The following is a description of a gene set: studied in species Homo sapiens The developmental process pertaining to the initial formation of an anatomical structure from unspecified parts. This process begins with the specific processes that contribute to the appearance of the discrete structure and ends when the structural rudiment is recognizable. An anatomical structure is any biological entity that occupies space and is distinguished from its surroundings. Anatomical structures can be macroscopic such as a carpel, or microscopic such as an acrosome. Human Gene Set: GOBP_ANATOMICAL_STRUCTURE_FORMATION_INVOLVED_IN_MORPHOGENESIS, and this is the list of marker genes: NINJ1, NTF4, KLHL12, ALOX5 (NCBI Gene Id 240), UNC5B, WASF2, EGR3, TP53, NAXE, AHDC1, PKM (pyruvate kinase M1/2), CDK5, DAG1, TNFRSF12A, HDAC2, NRXN3, FGFR2, ARHGAP35, FMNL3, WNT6, PKN1, HOXC11, GARIN1B, MYBPC3, JUNB, CFTR, MIR196A1, MIR885, RAMP1, TP63, NFATC4 (NCBI Gene Id 4776), NKX3-1, AGFG1, JAG1 (jagged canonical Notch ligand 1), MIR2355, APLNR, EDNRA, HRG, ATM, CDON, SMAD4, TUBB1, TWIST1, KRT19, NCL (nucleolin), AGTR1, POU5F1, COL15A1, DKK4, AGFG2, GDF15, MESP2, CACNA1S, CDK5R2, MIR329-1, CCBE1, HMOX1, PRKX, TBX5, TGFB3, SPEM3 (SPEM family member 3), TBXA2R, CLDN5, EXT2, ACRBP, PCDH8, SUPT6H, CARD10, ADAMTS15, PLXND1, POGLUT1, RDH10, ANXA2, GDF7, RELA, ADGRG1, LEO1, AKT3, PNLDC1, TXNRD1, MAPK1, LHX5, PTGS2, HMGA2, SHB, AMTN, TBX19, ITGA2B, MIR17, MIR149, ITGA4, HIPK2, OLFM1, KNDC1, CD93, SIX4, MIR1908, FLOT1, OVOL2, ARHGAP22, CASP9, GATA6, EPN2, COL5A2, TGFB1, SLC34A1, AMELX, ANXA3, SCGB3A1, SOX2, NUS1, ATP5F1B (ATP synthase F1 subunit beta), OBSL1, COL2A1, GATA3, IL17F, IRX2, HOXB3, BMP10, EREG, ACKR3, MINAR1, PLXNB2, RDH13, MMP19 (NCBI Gene Id 4327), WNT2B, STRA6, HESX1, BCL2L11, SCRIB, CCDC42, TGFBR1, TCF15, NECTIN2, MTHFD1, PTK2, SERPINF1, CCN1, NKX2-5, POLR1B, NPR3, PGM5, VEGFA, CD34, PGF, CDH13, FGFR1, NF1, MIR19A, NR5A2, HSPB1, LHX1, OBSCN, HS6ST1, RRAS, PRKACA, CX3CL1, NRCAM (NCBI Gene Id 4897), ALX1, POFUT2 (NCBI Gene Id 23275), LMOD1, SDCCAG8 (NCBI Gene Id 10806), YWHAZ, SOX30, GARIN3, NCKAP1, SOX9, EGLN1, NKX2-1, MDK, MIR377, TMOD4, THY1, RIPPLY1, CTNND1, ATP2B4, SPEM1, CCN6, PRCP, CUL3, NPPB, BCL3, IFT57, SIRT6 (sirtuin 6), WNK1, FLT1 (NCBI Gene Id 2321), PFN1, GARIN1A, MICALL1, NFATC2, SPECC1L, TMEM182, WNT3A, TGFBR3, TMIGD2, MAG, CFL1, HDAC7, NOX5, MAPK3, FURIN, TPM4, TMED2, PROX1, AMOTL2, TEK, APOD, MFAP2, CEND1, TWSG1, ITGA8, HDAC9, AGTPBP1, MIR34A, EYA2, CCN3, HDAC1, PLXNA2, ATP5IF1, AIMP1, PLEC, CDX2, ITGB5, MECP2 (NCBI Gene Id 8274), MIR24-1, MIR30B, VAV3, COL6A1, HES1, VANGL2, CASP8, ECSCR, SKOR2, HTN1, SCX, AGO2, COL1A1, WNT10B, CCDC136, ACVR2B, HES7, NLE1, LMOD3, ABCC8 (ATP binding cassette subfamily C member 8), FASLG, TBX3, LIAS, MIR296, ABI1, BMP4, IFT172, RTF1, TMPRSS12, COL5A1, PERP, CBLN1, NPPC, MMRN1, MIR214, ENSG00000285205, DSG2, FGF2, ELK3, SCG2, FOXF1, ANKRD23, B4GALT1, MIR185, RPL7L1 (NCBI Gene Id 285855, ribosomal protein L7 like 1), HSPG2, SKIL, PPARA, CD109, ADPRHL1, PKNOX1, BCAM, FZD4, MAPK7, RHOJ, CTR9, VTN, IL4R, GNA13, MIR10A, KBTBD8, SH3PXD2A, SPPL2C, ENPEP, SEMA5A, DLL1, MPL, CAPN2, WNT16, KLK4, FLNC, TCIRG1, EDA, HIF1A, MIR492, ITGAX, MYH11, TRAF6, TGFBR2, ADAM17, NCMAP, LOXL2, BMPER, CD36, MIR939, FGF9, COL8A2, NFE2L2, GATA5, MMP8, COL8A1, NBEAL2, ANXA1, ROBO1, MKS1, CEACAM1, CAMP, GDF3, MIR487B, NECTIN1, TMEM201, MIR375, RASIP1, PRKCA, PDCD6, DOCK1, CRB1, GPX1, MIRLET7F1, MEOX1, MIR378A, FBN2, HEY1, TSC1, ANGPT2, DUSP1, HHEX, PRKD2, ACTL9, SPRY1, COL18A1, LRP2, CITED2, SPINK2, FAM20C (FAM20C golgi associated secretory pathway kinase), NR4A1, SLC24A4, DLL3, TGFB2, FAM20A, GRHL2, NDP, EPAS1, MEOX2, PPARG, MIR126, OPTC, TGM2, LEP, RGMA, BCL6, CRB2, ESM1, PAFAH1B1, CDX1, WARS2, CNOT1, GBA1, DUSP4, PXDN, ITGB1, MEIS3P1, EPGN, ATP7A, AAMP, APOH, BMP7, MIR10B, ITGB4, CCL24, LATS2, CASP3, ZNF385A, RRP7A, PHOX2A, NKD1, MYH3, PTCH1, PAF1, COL11A1, ECM1, DSCAM, CCL11, PROK2, BMP2, BTG1, FKBP1A, PDGFRB, BBS4, IHH, DYRK1B (dual specificity tyrosine phosphorylation regulated kinase 1B), FHOD3, SLC12A6, CECR2, TERT, EHD2, TEAD2, CXCL8, SPINK5, PIK3R3, IL18, TJP1, FLT4, MIR29A, MSX1, ACTL7A, NOX1, WNT9B, HTATIP2, TREM2, CLUAP1, EGF, TNNT1, ACTL6A, MYL2, VEGFB, S100A1, ERCC2, ADAMTS9, MIR495, GLI3, NRAP (nebulin related anchoring protein), CYP19A1, SDK2, TNNT3, MIR31, GPC1, EGR2, ENG, ODAPH, F3, PTGFRN, PTPN11, GNPAT, ROCK1, PPP1R16B, SHC1, EIF2AK3, FGF8, SPINT2, SPINT1, TGFA, CALCRL, TIFAB (NCBI Gene Id 497189), LAMA3, HEYL, MIR146A, FGF18, SPHK1, MIR125B1 (NCBI Gene Id 406911), CSPG4, TCTN1, ENSG00000233887, STIM1, CRIPTO, TNN, PDGFB, MIR27B, ACTA1, MYF5, ACTG1, MIOS, ERAP1, SHH, ADM, CACNA1H, VEGFD, JMJD8, TBX18, SAT1, COL3A1, ETS2, KAT2A, MAP2K5, SLC39A12, SLC9A8, EPHA1, NGFR, APOLD1, PRKACB, RARG, TBR1, FZD7, GNAS, RARA, COL4A3, NEO1, HIPK1, EPHB3, MBOAT7, CCL8, CNTNAP1 (NCBI Gene Id 8506), APLN, CEP290, NOLC1, EXT1, PLXDC1, MIR320A, GLI2, PTPN20, CYBB, MYOZ2, FUT1, HSPB6, MED12, DOCK5, ZNF219, MIR101-1, ITGB8, MIR30A, SYNPO2L, C5AR1, TENM4, PEF1, FGF1, PDGFA, C1GALT1, DVL2, TNF, HIF3A, RAPGEF3, COL7A1, MIR34C, ANK2, ANPEP, CXCL10, SYNJ2BP, C3AR1, PIK3CG, SPTBN1, JUP, AMOT, KLHL41, IFT52, JAM3, VASH2, STAB1 (NCBI Gene Id 23166), RAMP2, NODAL, FLII, TMEM100, VASH1, WNT1, TCTA, POFUT1, TCAP, PDCD10, CCL2, TMEM215, NEUROG1, MIR30E, SEMA3C, EPHB1, PTPN6, ROBO4, FOXC1, ZNF354C, KDM6B, SDC4, CDC73, SEMA6A, LEPR (leptin receptor, NCBI Gene Id 3953), MIR20A, TAL1, MIR212, CCM2, MIR222, PMP22, GRN, FOXH1, HEY2, TCOF1, SULF1, ARHGAP24, ATOH8, CDH11, MIR26A1, TFAP2A, PLXNA3, OPHN1, EDN2, STAT3, HYAL1, LUZP1, TNMD, MTDH, MYBPC2, CC2D2A, ITGAV, EDAR, MED1, PIK3CD, DCN, RIPPLY2, SPRED1, NOTCH3, PRKDC, TBX6, SYK, VPS33A, KIF16B, WLS, NOTCH2, FOXJ1 (NCBI Gene Id 2302), MIR221, ANKRD1, MIR138-1 (NCBI Gene Id 406929), ZP3, RHOB, CASQ1, ADGRB3, GJA5, ITGB3, FAIM2, EFNA1, DEAF1, MIR515-1 (microRNA 515-1), CNMD, SETD2, MIRLET7B, MYOM2, EFNA3, ITGA5, MIR640, NKX3-2, OSR1, SFRP2, MIR1-1, MYOM1, MAPK14, WNT2, TBX20, TNFSF14, KIF20B, DUSP5, CELSR1, MATR3, MIR410, SLC25A46, CD47, GPNMB, SLC1A1, ST14, PTF1A (NCBI Gene Id 256297), CFLAR, PROK1, ROBO2, TBPL1, TGFBI, MCAM, ARL6, HSPA12B, EDN1, TPPP, E2F8 (E2F transcription factor 8), TULP3, RECK, MIR181B1, PANK2, EFNB2, VPS4B, SPARC, TSPAN12, THBS1, SPACA1, FAT3, BCAS3, EMILIN1, CXCL17 (NCBI Gene Id 284340), MIR200C, SEMA3E, TSPAN18, SUFU, RTN4, XRCC2, PIK3CA, MSX2, NFIB, THBS3, SOX11, ADAMTS1, CHI3L1, CCR2, ADAM12, SP1, NOTCH4, NDNF, CELA1, SOX18, TRIM15, NRP1, JMJD6, FRS2, AXIN2, NAA15, SERPINE1, HES5, TFAP2C, ISM1, SNAI1, ATF2, RBP4, PLA2G3, E2F7 (E2F transcription factor 7), NOS3, SSBP3, MIR18A, HGS (hepatocyte growth factor-regulated tyrosine kinase substrate), LRG1 (leucine rich alpha-2-glycoprotein 1), EXOC4, GHSR, SDK1, IL10, MIR503, RNF213, TEAD4, KLF5, WT1, SASH1, PODXL, NFKB2, VPS13B, PDPK1, VEGFC, ACTN2, MYMX, GDF2, DLX5, THBS4, MYMK, FGF16, DOCK2, TBX1, MIR16-1, RC3H1, ERVW-1, ITGA3, BMPR1A (bone morphogenetic protein receptor type 1A), XBP1, MIR483, PLK2, FBLN5 (NCBI Gene Id 11268), AMOTL1, APAF1, PTPN18, MIR21, SLC31A1, ACVR1, EPHB2, SFRP1, KLK5, ERVFRD-1, PPP2R3A, RS1, CCN2, CYP1B1, SALL4, TYROBP, STARD13, BMP5, MPIG6B, PRKCB, SIX2, MIR494, MYPN, AGGF1, GSC, LARGE1, RNH1, ZNF304, ANGPTL4, RORA, PLCD3, DAB2IP, CTNNB1, ID1, SALL1, AQP1, EMILIN2, EPB41L3, STIL, ACTC1 (actin alpha cardiac muscle 1), MMP20, FOXA1, HNF1B, SKI, SEC24B, FZD6, MIR92A1, ANGPTL6, TFAP2B, CXCR3, ABL1, PLEKHO1, ELF5, DCSTAMP, MFNG, PRKD1, RELN, GPR15, MIR193A (NCBI Gene Id 406968), MIRLET7A1, GCM1, BYSL, TTLL1, KLF2, FOXC2, IL12A, PPP3R1, CD40, MYBPC1, CHAD, FZD3, MIR19B1, ALDH1A3, TTN, FOXP2, FOXB1, QKI, TANC1, SIRT1, CD81, CCDC38, CD160, MESP1, MEF2C, KNL1, IRX3, PTPRB, WHRN, ETS1, RLN2, IL12B, MIR99B, ADGRA2, SRPX2, FOXN4, THBS2, MTHFR, PIK3R6, MFSD14A, PDCL3, SPRY2, GABPA, PRL, EOMES, FGF10, SF3B6, FKBPL, JCAD, TLR3, HOXA11, MSGN1, WNT7A, FHL2, LHX2, MMRN2, CTHRC1, LAMB1, DMP1, ROGDI, DCAF17, LRP8, OTX2, ANGPTL3, GHRL, HOXA7, KRT1, EMC10, MAP2K1, HAND2, PIK3CB, FOXO4, NRXN1, BRCA1, CD53, PFN4, MIR1224 (NCBI Gene Id 100187716), RBM15, ERVH48-1, UBP1, FYN, HS2ST1, MIR143, DAB1, MIR205, RSPO3, SMARCD3, E2F2, MEF2A (myocyte enhancer factor 2A), TNFAIP3, THSD7A (thrombospondin type 1 domain containing 7A), RALA, SIX1 (SIX homeobox 1), PLN, BMERB1, TLX2, PPP3CB, HAND1, MIR137 (NCBI Gene Id 406928), HOPX, PIK3C2A, MIR424, UNC13D, MIR150, SMAD2, MYF6, LFNG, MIR29C, ITGB6 (NCBI Gene Id 3694), TNNT2, CAPN3, LEF1, TET1, PRKAR1A, PALS1, DCANP1, GTF2I, MIR20B, SRF, GJA1, COL4A2, FOXJ2, SEMA4C, PRDM14, C3 (NCBI Gene Id 12266), ADGRB2, CSRP2, STK3, RPS7, MAP2K2, ADGRB1, ADAM9, PECAM1, MIRLET7G, YAP1, MIR1298, PAK4 (p21 (RAC1) activated kinase 4), IFT122, PIM1, VAV2, ADAM15 (NCBI Gene Id 8751), FOXA2, HSBP1, IZUMO1, CAMK1, NPR2 (NCBI Gene Id 4882), SOCS7, HERC1 (NCBI Gene Id 8925), SOX17, CYLC1, POC1B, FZD8, CSRP3 (NCBI Gene Id 8048), NR0B1, MIXL1, ISL1, CEMIP2 (cell migration inducing hyaluronidase 2), PARVA, CAV1, GLMN, TTC21B (NCBI Gene Id 79809), CDK5R1, MIR505, GRID2, NRARP, TBX2, CREB3L1, COBL, DUSP2, ADAMTS5, AMELY, ADM2, CNTN1, ACVRL1, MIR130A, KLHL6, MIR200B, KLF4, CFL2, MIR106B, MIB1, SLC12A2, MYOD1, OTULIN, SLIT2, RBPJ, CAV3, PML, UGT8, TNFAIP2, SMO, HOXA1, RELT, ATP8B1, PAX6, PACSIN2, HLA-G, VASP, IL1B, KCNH1, PROM1, SMAD3, COL12A1, MFGE8, SRPK2, ROCK2, NR4A3, MIR342, PTK7, FJX1, PF4, MIR34B, NEBL, CCDC134, NUP50, SMOC2 (SPARC related modular calcium binding 2), KDM2B, AKT1, AGO1, CDH5, BSG, SBNO2, EPB41L5, MIR132, MIR22, S100A7, MIR217, BMPR2 (NCBI Gene Id 659), MMP2, MYOG, MYH9, CXCL9, JAK1, DLC1, WDR74, RBM46, DLX6, CSF3R, WARS1, INHBA, MAFB, MFN2, MXI1, AR, RGCC, CLEC14A, MIR145, TBX4, GADD45A, TNFSF13B, CLEC1B, IGFBP7, GATA1, TIE1, PTPRJ, VEZF1 (NCBI Gene Id 7716), FZD5, TBC1D20, EMP2, IZUMO3, WDR83, TGIF1, ANGPT4, TM4SF1, PLXNA1, PDGFRA, HMGB1, GPR4, GPI, TCF21, MIA3, LATS1, MEGF11 (NCBI Gene Id 84465), TSC2, MYL9, TMF1, CNOT2, FGFBP1, IL1A, MMP15, ZC3H12A, SP3, MIR30C1, MIR361, SLC40A1, ZPBP2, WNT5A, GPLD1, ESRRB, ACTN1, MTHFD1L, ITGB1BP1, PTPN14, ZFPM1, ANG, TMOD1, MYOM3 (myomesin 3), KDM4C, HOXB13, MYH10, MACROH2A1, WNT4, ABCA2, SMPD3, TNFSF12, SLC4A2, IL6, NOS1, MEIS3, FAP, LEMD2, NOG, DSPP, CX3CR1, IRX1, HPSE, PLCG1, JUN, MYOZ1, APELA, GREM1, GBX2, ENAM, EHD1, OPA1, TAFA5, MYLK3, KRIT1, CNOT3, DMRT2, CDK20, STAB2, MIR23A, MIR199A1, KIF26B, EPHA2, MTMR2, EPHB4 (EPH receptor B4), TPM1, RET (NCBI Gene Id 5979), MYH6, DCHS1, ADTRP, YJEFN3, PAX8, CHRNA7, PTK2B, MIR199B, MIR451A, GDNF, RHOA, PDCL2, ZEB2, RBM20, FIG4 (NCBI Gene Id 9896), GATA4, FOLR1, NRP2, NR2E1, CNNM4, ITGA7, GLUL, WDR1, CLIC4, TYMP, WNT8A, KLK3, STAT1, PTGIS, GRHL3, PDE3B, GAB1, MIR27A, MYBPH, PRICKLE1, PSEN1, EPN1, SLC44A4, NPR1, ADGRG6, GATA2, TRIM71, BRD2, MMP14, MIR210, HOXB1, SOX8, MIR9-1, ETV2, SNAI2, ADAM8, AHI1, CXCL13, TAF10, ITGA2, SMAD1, MYDGF, SEMA4A, FOXD1, CIB1, MIR125A, AXIN1, ERBB2, CCNB1IP1, NPHS1, OCSTAMP, TBXT, FN1, KIAA0319L, NRG3, ARMC5, OR10J5, CALB1, S1PR1, EGFL7, PGK1, WNT3, ZIC3, COL4A1, ATP8A2, NANOG, HOXA5, LRP6, MIR15B, ANGPT1, SH2D2A, SARS1, C12orf43, RFX2, NF2, ADA, TMOD3, LDB1, CLIC3, RIPOR2, MIR206, TMOD2, HOXA3, GRB2, PITX2, NEB, PLLP, HK2, DICER1, NTRK1, ITGB2, ZPBP, BRD3, EHD4, ERCC1, STK4, PAX2, LMOD2, AKAP13, LMO4 (NCBI Gene Id 8543), SOX7, FGF6, BCL10, PDPN, LDB3, ADIPOR2 (adiponectin receptor 2), NOTCH1, DKK1, EYA1, PHACTR4, CCR3 (NCBI Gene Id 1232), SP100, MINAR2, FUZ, MIR15A, CMA1, MMP9, LAMB3, CHN2, PTPRM, DLL4, CD9, RUNX1, VSTM4, WNT11, DDAH1, EP300, CSRP1, KDR (NCBI Gene Id 3791), PALB2, HDAC5, MEIS1, MIR497